Given this list of marker genes MAOB (NCBI Gene Id 4129), MAOA, SMOX, ALDH7A1, SLC44A1, PAOX, PDE1B, MIR21, CHDH, SULT1A3, SULT1A1, SAT1, HNMT, SULT1A4, SLC6A3, DHPS (NCBI Gene Id 1725), MOXD1 (monooxygenase DBH like 1), DMGDH, COMT (NCBI Gene Id 1312), ATP2B4, DBH, MOXD2P, here is a description of the gene set: studied in species Homo sapiens The chemical reactions and pathways resulting in the breakdown of any organic compound that is weakly basic in character and contains an amino or a substituted amino group. Amines are called primary, secondary, or tertiary according to whether one, two, or three carbon atoms are attached to the nitrogen atom. Human Gene Set: GOBP_AMINE_CATABOLIC_PROCESS